The following is a description of a gene set: studied in species Homo sapiens Facial myokymia is a fine fibrillary activity of one or more muscles innervated by the facial nerve (the seventh cranial nerve). Human Gene Set: HP_FACIAL_MYOKYMIA Facial myokymia, and this is the list of marker genes: ABCD1, PNPT1, ATP13A2, ADCY5, PPP2R2B, SPTBN2, PRKCG, LGI3